Given this list of marker genes KDELR3, CNTNAP1, PVALB, ELOA (NCBI Gene Id 6924), RNLS, NCAN, ARL5B, SLC6A17, RNF125, CDK18, STC1, ENTPD2, PPT2, INAVA, WNT7B, FILIP1L, RFX3, NAPG, RDX, LPGAT1, GUCA1B, PPP2R2D, MSS51, NABP1, ACTB, NFIX, MPZ (NCBI Gene Id 4359), NFASC, COPG1, SHISA7, SHISAL1, CASTOR2, ARHGEF10, DSG3, NAPA, MECP2, STIM2, here is a description of the gene set: Genes predicted to be targets of miRBase v22 microRNA hsa-miR-4525 in miRDB v6.0 with MirTarget v4 prediction scores > 80 (high confidence targets). Human Gene Set: MIR4525 species: Homo sapiens from publication Chen Y, Wang X (PMID 31504780)